The following is a description of a gene set: Human Gene Set: MIR3161 from publication Chen Y, Wang X (PMID 31504780) species: Homo sapiens Genes predicted to be targets of miRBase v22 microRNA hsa-miR-3161 in miRDB v6.0 with MirTarget v4 prediction scores > 80 (high confidence targets)., and this is the list of marker genes: NT5C1B, CS, RBM12, ABCC4, LRRN1, RASA2, COL11A1, ADAM12, SP3, AHR, MAP3K20, OAS2, MED14OS (NCBI Gene Id 730648), SIRT5, RAPH1, ZFP36L1, GRB14, ZNRF3, USP8, RICTOR, ANO6, CBR1, CORO2B, SCN9A (NCBI Gene Id 93955), RPS6KA6, NOL11, FZD3, BOLL, OPCML, TSEN34, CSNK1G3, ERCC6L2, BCL2, C1orf141, LRRTM4, MKLN1, PLCL1, ARHGEF28, ITGB8, RTL3, FN1, PLCXD3 (phosphatidylinositol specific phospholipase C X domain containing 3), LILRA1, NUS1, ANO5, RMDN2, SLC10A7, PICALM, GRIK2, YIPF5, RAB10, ERLIN1, H1-8, ZDHHC17, RRAS2, TUBE1, SLC35F2, EMC3, PRKCB, ANGEL2, ST6GALNAC3, ANP32E (acidic nuclear phosphoprotein 32 family member E), ARHGEF40, OR51E1, EBF1, ABI3BP, VPS4B, TNFRSF1B, PHYHIPL, ZNG1E, EIF5A2, ADRA2B, ASB5, GTF2B, PPARGC1A